Given this list of marker genes PAK1, ARHGEF28, LYN, EFNB1, EFNB2, EPHB6, ROCK2, RHOA, EPHB3, ACTR2, EPHB2, ARPC4, KALRN, CFL1, ARPC3, ROCK1, LIMK1, EPHB1, LIMK2, ITSN1, SDC2, SRC, PTK2, YES1, ARPC5, RAC1, ARPC1B, ACTG1, EPHB4, FYN, HRAS, EFNB3, WASL, ARPC1A, RASA1, TIAM1, ARPC2, GRIN1 (NCBI Gene Id 2902), ACTB, ACTR3, GRIN2B, CDC42, here is a description of the gene set: part of: EPH-Ephrin signaling studied in species Homo sapiens Reactome Pathway: EPHB-mediated forward signaling Multiple EPHB receptors contribute directly to dendritic spine development and morphogenesis. These are more broadly involved in post-synaptic development through activation of focal adhesion kinase (FAK) and Rho family GTPases and their GEFs. Dendritic spine morphogenesis is a vital part of the process of synapse formation and maturation during CNS development. Dendritic spine morphogenesis is characterized by filopodia shortening followed by the formation of mature mushroom-shaped spines. EPHBs control neuronal morphology and motility by modulation of the actin cytoskeleton. EPHBs control dendritic filopodia motility, enabling synapse formation. EPHBs exert these effects through interacting with the guanine exchange factors (GEFs) such as intersectin and kalirin. The intersectin-CDC42-WASP-actin and kalirin-RAC-PAK-actin pathways have been proposed to regulate the EPHB receptor mediated morphogenesis and maturation of dendritic spines in cultured hippocampal and cortical neurons (Irie & Yamaguchi 2002, Penzes et al. 2003). EPHBs are also involved in the regulation of dendritic spine morphology through FAK which activates the RHOA-ROCK-LIMK-1 pathway to suppress cofilin activity and inhibit cofilin-mediated dendritic spine remodeling.